The following is a description of a gene set: Mouse Gene Set: CUI_CDC1_IL27_RESPONSE_DN from publication Cui A, Huang T, Li S, Ma A, Pérez JL, Sander C, Keskin DB, Wu CJ, Fraenkel E, Hacohen N (PMID 38057668) Cytokines mediate cell-cell communication in the immune system and represent important therapeutic targets. A myriad of studies have highlighted their central role in immune function, yet we lack a global view of the cellular responses of each immune cell type to each cytokine. To address this gap, the authors created the Immune Dictionary, a compendium of single-cell transcriptomic profiles of more than 17 immune cell types in response to each of 86 cytokines (>1,400 cytokine-cell type combinations) in mouse lymph nodes in vivo. A cytokine-centric view of the dictionary revealed that most cytokines induce highly cell-type-specific responses. For example, the inflammatory cytokine interleukin-1β induces distinct gene programmes in almost every cell type. A cell-type-centric view of the dictionary identified more than 66 cytokine-driven cellular polarization states across immune cell types, including previously uncharacterized states such as an interleukin-18-induced polyfunctional natural killer cell state. Genes negatively differentially expressed in cell type: cDC1 (conventional dendritic cell type 1) upon treatment with cytokine: IL-27 in mouse lymph nodes in vivo. studied in species Mus musculus, and this is the list of marker genes: Hspa1b, Jun, Arhgap5, Fosb (NCBI Gene Id 14282), Kctd12, Hspa1a, Klf4, Fos